Given this list of marker genes PTRH2, UST, HR, CYP4F22, ATRIP, PADI3, LETM1, TUBA3C, MCM7 (NCBI Gene Id 4176), GINS2, CTSD, FAAP100, TSKU, CYP1B1, ADAMTSL5, WWC1, KCNK6, CERS1, KRT15, SLC2A8, SPINK4, ZNF703, HOMER3, LRG1, WDR46, OLFML3, SBNO2, ASB13, GADD45B, HK2, SYNDIG1, TGM2, UNC119 (NCBI Gene Id 9094), AATF, MAPT, TPBG, CCDC3, FUT4, EFHD2, SLC1A4, PKIB, LRFN4, DOK7, MYBBP1A, SIN3B, C1QTNF6, EIF3B, TMEM51, UNC5A, BEGAIN, FCMR, IER5L, BCL11B, SIAH2, RTKN, SYBU, EEIG1, SYT12, C1orf159, SLC2A1, GSG1L, SH2B2, UHRF1, PLEKHH1, KDM4B, E2F2, TENT5C, PPARGC1B, UBALD1, DHRS3, HLA-DRB1, HCK, FLNB, KAZN, SEPTIN9, SLC7A6, LHX4, VGF, CLUH, WNT4, TJP3, CXXC5, ADARB1, SNX24 (NCBI Gene Id 28966), IER3, WFS1, HPDL, KLC1, HDAC4, PODXL, NOD2, TWNK, SUSD3, C16orf74, RPP40, SLC7A5, IGFBP4, GDF15, NADSYN1, PAK4, SLX9, SCNN1B, SCARB1, NUDCD1, TPD52L1, ATP6V1C2, TUBB2B, GFOD1, ZFP36L1, KRT13, XBP1, PTH1R, STK24, CALM1, FCHO1, RARA, PMM2, RGS16, TRMT61A (tRNA methyltransferase 61A), NHERF1, PDZK1, FOS, SLC6A6 (solute carrier family 6 member 6), MFSD2A, SEC14L2, ALDH3B1, REEP1, ARAP3, POP1, GNL2, AXIN1, SRM, FLAD1, DUSP2, BRD9, KCNK15, PARP12, RECQL4, PAM16, MTFP1, HROB, RIMS4, PITX1, RRP12, PRKAG2, AKNA, SCNN1A, PA2G4, HPCAL1 (NCBI Gene Id 96763), ATF3, RUVBL1, UBIAD1, MPPED2, PDLIM3 (NCBI Gene Id 27295), GPRIN1, ADAP1, TBX2, SLC10A3, TGIF2, LTBP3, ZNF185, MED24, OVOL2, VWF, GREB1, KHK, NIP7, SMTNL2, CHD9, PRR5, FGFRL1, RAB11FIP3, KLK10, JADE2, INO80B (INO80 complex subunit B), PTGES (NCBI Gene Id 9536), MAG, HSD11B2, IFRD1, TOE1, DEGS2, NEIL2, IL20, HSPB8 (heat shock protein family B (small) member 8), CDC42EP1, NCOR2, GAB2, SH2D2A, LONRF2, GADD45G, BHLHE40, SLC25A25, GPATCH4, CHST8, TBC1D16, CCND1 (NCBI Gene Id 893), CCNP, TH, DHRS2, SULT2B1, SLC29A1, FARP1, STC2, ISG20L2, NXT1, SLC7A2, OSGIN1, CDC6, GATAD2A, LRIG1, ALPL, NOL6, ACIN1, XRCC3, POLR1B, MYB, NUDC, LMO1, B4GALT1, FHL2, MRPS17, STX1A, ADCY9, PGR, TMEM104, BRINP2, ARMC6 (armadillo repeat containing 6), MCRIP2, MANEAL, GPR37L1, TIAM1, IMP4, CYP4F11, CBFA2T3, TMEM120B, TIPARP, CNKSR3, AP1B1, SLC22A5 (solute carrier family 22 member 5), CAMTA1, PIP4K2A, CA12 (NCBI Gene Id 771), NT5DC3, CDC34, QSOX2, RET, MSMB, RCL1, CCM2L, RAPGEFL1, SVIL, AMZ1 (NCBI Gene Id 155185), THOC5, ADCY3, PCYT2, PPIF, CARD19, NMRK1, TBKBP1, UBQLN4 (ubiquilin 4), CELSR2, MLPH, NOP14, TFF2, SEMA3B, CYP26A1, RNF144A, MYEOV, C5AR2, ARHGEF18, GLA, SHB, NCS1, FKBP4, PPRC1, NOLC1, TRIM47, TOMM40, MAT2A, EIF2S1, A4GALT, here is a description of the gene set: species: Homo sapiens Estrogen regulates several biological processes through estrogen receptor alpha (ERalpha) and ERbeta. ERalpha-estrogen signaling is additionally controlled by extracellular signal activated kinases such as AKT. In this study, we analyzed the effect of AKT on genome-wide ERalpha binding in MCF-7 breast cancer cells. Parental and AKT-overexpressing cells displayed 4,349 and 4,359 ERalpha binding sites, respectively, with approximately 60% overlap. In both cell types, approximately 40% of estrogen-regulated genes associate with ERalpha binding sites; a similar percentage of estrogen-regulated genes are differentially expressed in two cell types. Based on pathway analysis, these differentially estrogen-regulated genes are linked to transforming growth factor beta (TGF-beta), NF-kappaB, and E2F pathways. Consistent with this, the two cell types responded differently to TGF-beta treatment: parental cells, but not AKT-overexpressing cells, required estrogen to overcome growth inhibition. Combining the ERalpha DNA-binding pattern with gene expression data from primary tumors revealed specific effects of AKT on ERalpha binding and estrogen-regulated expression of genes that define prognostic subgroups and tamoxifen sensitivity of ERalpha-positive breast cancer. These results suggest a unique role of AKT in modulating estrogen signaling in ERalpha-positive breast cancers and highlights how extracellular signal activated kinases can change the landscape of transcription factor binding to the genome. Human Gene Set: BHAT_ESR1_TARGETS_VIA_AKT1_UP Genes bound by ESR1 and up-regulated by estradiol in MCF-7 cells (breast cancer) expressing constitutevly active form of AKT1. from publication Bhat-Nakshatri P, Wang G, Appaiah H, Luktuke N, Carroll JS, Geistlinger TR, Brown M, Badve S, Liu Y, Nakshatri H (PMID 18838536)